The following is a description of a gene set: species: Mus musculus Mouse Gene Set: GOBP_POSITIVE_REGULATION_OF_NUCLEAR_CELL_CYCLE_DNA_REPLICATION Any process that activates or increases the frequency, rate or extent of the DNA-dependent DNA replication that occurs in the nucleus of eukaryotic organisms as part of the cell cycle., and this is the list of marker genes: Ino80, Cdc7, Dbf4, Fgfr1, Wiz, Atrx